Given this list of marker genes APOO, YRDC, TESK1, DYNC1LI1, BCL10, GPR161, AP1S1, NSUN3, ING2, FOSL1, PDLIM5, HBEGF, DUSP6, TRIM21, ENC1, BAX, IL1B, SPRY4, EPOR, ALDH1A3, TXNRD1, EREG, PTPA, SH2D3A, EIF1, MRGBP, MAFF, PCBD1, LSM4, EPHA2, RPS6KA4, CCL20, PHLDA3, NAP1L1, PLAUR, GDF15, CDV3 (NCBI Gene Id 55573), LIF, SDHAF1, IL1A, SERPINB2, here is a description of the gene set: from publication Amit I, Citri A, Shay T, Lu Y, Katz M, Zhang F, Tarcic G, Siwak D, Lahad J, Jacob-Hirsch J, Amariglio N, Vaisman N, Segal E, Rechavi G, Alon U, Mills GB, Domany E, Yarden Y (PMID 17322878) Human Gene Set: AMIT_EGF_RESPONSE_120_MCF10A studied in species Homo sapiens Signaling pathways invoke interplays between forward signaling and feedback to drive robust cellular response. In this study, we address the dynamics of growth factor signaling through profiling of protein phosphorylation and gene expression, demonstrating the presence of a kinetically defined cluster of delayed early genes that function to attenuate the early events of growth factor signaling. Using epidermal growth factor receptor signaling as the major model system and concentrating on regulation of transcription and mRNA stability, we demonstrate that a number of genes within the delayed early gene cluster function as feedback regulators of immediate early genes. Consistent with their role in negative regulation of cell signaling, genes within this cluster are downregulated in diverse tumor types, in correlation with clinical outcome. More generally, our study proposes a mechanistic description of the cellular response to growth factors by defining architectural motifs that underlie the function of signaling networks. Genes whose expression peaked at 120 min after stimulation of MCF10A cells with EGF.